Given this list of marker genes Man2a2, Nr0b1, Cldn11, Gdnf, Sf1, Rbp4, Lhcgr, Hmga1, Dhh, Gja1, Inha, Acvr2a, Map7, Serpina5, Gdi1, Cyp17a1, Bcl2l2, Slc12a2, Ar, Dnaja1, Sbf1, Cyp19a1, Sox8, Hmgb2, Cdkn2c (cyclin dependent kinase inhibitor 2C), Kitl, B4galnt1 (beta-1,4-N-acetyl-galactosaminyl transferase 1), Dmrt1, here is a description of the gene set: Mouse Gene Set: MATZUK_MALE_REPRODUCTION_SERTOLI Reproduction is required for the survival of all mammalian species, and thousands of essential 'sex' genes are conserved through evolution. Basic research helps to define these genes and the mechanisms responsible for the development, function and regulation of the male and female reproductive systems. However, many infertile couples continue to be labeled with the diagnosis of idiopathic infertility or given descriptive diagnoses that do not provide a cause for their defect. For other individuals with a known etiology, effective cures are lacking, although their infertility is often bypassed with assisted reproductive technologies (ART), some accompanied by safety or ethical concerns. Certainly, progress in the field of reproduction has been realized in the twenty-first century with advances in the understanding of the regulation of fertility, with the production of over 400 mutant mouse models with a reproductive phenotype and with the promise of regenerative gonadal stem cells. Indeed, the past six years have witnessed a virtual explosion in the identification of gene mutations or polymorphisms that cause or are linked to human infertility. Translation of these findings to the clinic remains slow, however, as do new methods to diagnose and treat infertile couples. Additionally, new approaches to contraception remain elusive. Nevertheless, the basic and clinical advances in the understanding of the molecular controls of reproduction are impressive and will ultimately improve patient care. Genes important for Sertoli, peritubular, Leydig and interstitial cells, based on mouse models with male reproductive defects. studied in species Mus musculus from publication Matzuk MM, Lamb DJ (PMID 18989307)